Given this list of marker genes GPR137B, SRMS, SEH1L, LARS1, USP4, SESN2, KLHL22, FNIP2, OGT, RRAGD, RRAGA, OTUB1, FNIP1, SLC38A9 (NCBI Gene Id 153129), CASTOR1, SIK3, CUL3 (NCBI Gene Id 8452), LAMTOR2, SYK, WAC, PIH1D1, LAMTOR5, MAT2A, MIOS, TBK1, SHQ1, RNF167, OTUD5 (OTU deubiquitinase 5), PIM1, EP300, LAMTOR4, PRMT1, STAMBPL1, CTNS, CLEC16A, FLCN, PIP4P1, CSNK1A1, LAMTOR1, WDR59, USP32, RPS6KB1, RBX1, SRC, RHEB, GPR137, AKT1, RRAGC, SAMTOR, GPR137C, GPR155, WDR24 (WD repeat domain 24), RRAGB (Ras related GTP binding B), SEC13, LAMTOR3, here is a description of the gene set: Any process that activates or increases the frequency, rate or extent of TORC1 signaling. species: Homo sapiens Human Gene Set: GOBP_POSITIVE_REGULATION_OF_TORC1_SIGNALING